Given this list of marker genes TMEM60, NHLRC2, MIA3, SORL1, BOC, USP36, COX7A2, SYT11, RABGAP1L, NUDT21, A4GNT, OSTC, UQCR11, SMIM5, NDUFB3, CETN3, ZSCAN20, ARMC2, TMA7, PSMA6, RRP15, STK4, POLDIP3, DCN, RAD1, UGT2A3, CTDP1, PSMD6, KRIT1, RBM15B, CHURC1, DDX18, ABCG1, CISD1 (NCBI Gene Id 55847), UBE2F (ubiquitin conjugating enzyme E2 F (putative)), SRP9, SLC4A7 (solute carrier family 4 member 7), HNRNPA0, TMEM45A, MZT1, RPL31, ARAP2, ROMO1, NDUFB11, TEX38, HAS2, TTC14 (NCBI Gene Id 151613), BRD3, ZFPM1, ELAVL4 (ELAV like RNA binding protein 4), SEMA3E, YOD1, GSX2, TAFA3, PTPRE, IL22RA2, CASP8AP2, HAO1, ZFP64, GAPVD1, ABI2 (abl interactor 2), TMEM150B, CCDC38, CYB5R4, RRS1, TMED7, ZNF841, SPIN4, CNOT6, NDUFA2, SEPTIN10, PPIA, DUSP4, ATP5MG, GCSH, MAGI3, EHD3, CWC15, EIF1AX, ATOH1, TMPRSS5, MID1, EIF3B (NCBI Gene Id 8662), DR1, POLR2H, ATP5MC3, GTF2H5, BCOR, LORICRIN, TMEM41A, RHOF, DZANK1, VAMP7 (vesicle associated membrane protein 7), CACNA2D2, GRIN3B, SSR2, GRPEL1, NHP2, RNF182, EIF5B, CMC2, UROC1, MED30, UNG, MAGOH, EXOC4 (exocyst complex component 4), THEMIS, NAPB, NDUFAF8, IKZF1, PDGFD, MAB21L2, NDUFB5, FIBIN, DNAJC15, CPNE5, DUT, FBXO8, PNO1, ABRACL, LCOR, RAP1B, NOL7, RRAGD, TIRAP, ZNF287, ZNF560, HNRNPK, ARHGAP29, CSF2RB, COX7B2, PSMG4, EHD2, POLE3, NPHS2, SLC25A15, KRR1, ATP6V0C, NBEAL1, C21orf91 (NCBI Gene Id 89755), MAT2A, IRX2, PODXL2, SPECC1L, KIF26B, TPBG, CCDC88A, MED13L, DIAPH3, MFAP3, HLF, HCCS (NCBI Gene Id 4307), RPL36A, RBM12, EFR3A, IGF1R, NDUFC1, CHAMP1, DEPP1, MED18, SON, SUFU, DDX3X, LAMTOR1, MICOS10, NDUFB6, CSTB, EIF3E, TRAPPC10, SYDE2, JAK1, NDUFB8 (NADH:ubiquinone oxidoreductase subunit B8), CEMIP2 (cell migration inducing hyaluronidase 2), SLC35G6, FABP5, UCN, GAS2L3 (NCBI Gene Id 283431), L3MBTL3, CHIA, FAM162A, MRPS28 (NCBI Gene Id 64947), FAM83G, RPS26, CCT6A, IER5, LRRC3B, TRMT6, EFTUD2, OLIG3, POLR1F, SEC23B, PDK1, SYP, MPC2, GANC, TDO2, DAD1 (defender against cell death 1), RPP25, E2F5, CADPS2, here is a description of the gene set: Genes up-regulated in monocytes (12h) versus macrophages (12h) treated with IL4 and rosiglitazone. species: Homo sapiens Human Gene Set: GSE16385_MONOCYTE_VS_12H_ROSIGLITAZONE_IL4_TREATED_MACROPHAGE_UP from publication Szanto A, Balint BL, Nagy ZS, Barta E, Dezso B, Pap A, Szeles L, Poliska S, Oros M, Evans RM, Barak Y, Schwabe J, Nagy L (PMID 21093321) Human CD14 positive monocytes were purified from healthy volunteers’ blood and cultured in vitro for 4, 12, 24, 72 hours. While culturing, macrophages were activated alternatively with interleukin-4 (IL-4 100 ng/ml) or classically with interferon-gamma (IFNg 100 ng/ml)+tumor necrosis factor (TNF 50 ng/ml) or left without activation. Simultaneously, macrophages were also treated with vehicle (DMSO:ethanol) or 1mM synthetic PPARg agonist, Rosiglitazone. We used Affymetrix microarrays (U133Plus 2.0) to analyze activation and PPARg-induced gene expression changes.